The following is a description of a gene set: species: Mus musculus Mouse Gene Set: GOBP_FIBROBLAST_APOPTOTIC_PROCESS Any apoptotic process in a fibroblast, a connective tissue cell which secretes an extracellular matrix rich in collagen and other macromolecules., and this is the list of marker genes: Casp3 (caspase 3), Socs1, Trp53, Pmaip1, Chd8, Cul3, Ier3ip1, Prdm11, Stk17b, Bcl2l11, Sfrp1, Sirt1, Pik3ca, Casp7, Bbc3, Nupr1, Pik3cg, Bak1, Bid, Ddias, Btg1, Casp9, Apc, Casp12, Xrcc2, Gas6, Cfdp1, Men1, Bcl10, Trp63, Api5